Given this list of marker genes ANKRD29, SIRT3, ZHX1, SMPD3, NFE2L3, SPRY3, RPL32, ARRDC3, PI4K2B, CREB5, PANK3, LMTK2, DNAJC1, ZNF577, ATP6V1C2, GUCY1A2, KLF9, THSD7A, SORCS1, NECTIN3, ZBTB41, ANKRD45, NHLH2, SFR1, ADAM22, PIGA, MGA, GABRG2, RELN (NCBI Gene Id 5649), ABAT, ORC5, TNK1, AGO4 (argonaute RISC component 4), CAV1, CHFR, RCC2, FYB2, SACM1L, IQCH, TNS1, CCDC80, ACSL1, KCNK10, TBXAS1, DCX, ZCCHC2 (NCBI Gene Id 84810), DMRTC2 (DMRT like family C2), EPHA5, GPR55, MSL3, GID4, MIER1, ZNF503, FGF12, ZIC5, PPP1R2, BNC2, ETF1, RNF217, RORA, PDGFRA, ZNF678, DUSP19, RALGAPB, CNDP2, GLI2, UNC5B, LDAH, VIPAS39, ARID2, BMPR2, CYBRD1 (NCBI Gene Id 79901), RGS6, CCDC34 (NCBI Gene Id 91057), CALHM5, ZBTB21, NSF, UBR3, ATP8A1, VIRMA, TBX3, AAK1, ZBTB34, GLUD1, CYSTM1, DAAM1, RPS6KB1, DCP1B, AMD1, NOTCH1, SLC44A1, PPARGC1A, IGSF10, PHF20, OGA, ADAMTS13, BHLHE22, CDKL3, CCL16, GCLM, PALMD, DAB2, BCAP29, RAP1B, SLC25A27, CBFA2T3, IKZF2, PIK3CA, TSR1, NAPB, MSRB2, ACSL5, USP27X, PJA1, CRACD, NFIB, GATA6, PRPF18, PUS3, GPT2 (glutamic--pyruvic transaminase 2), MTMR3, MBD5, here is a description of the gene set: Genes predicted to be targets of miRBase v22 microRNA hsa-miR-7850-5p in miRDB v6.0 with MirTarget v4 prediction scores > 80 (high confidence targets). Human Gene Set: MIR7850_5P studied in species Homo sapiens from publication Chen Y, Wang X (PMID 31504780)